The following is a description of a gene set: Human Gene Set: GSE24292_WT_VS_PPARG_KO_MACROPHAGE_DN Genes down-regulated in macrophages: wildtype versus PPARG knockout. from publication Roszer T, Menéndez-Gutiérrez MP, Lefterova MI, Alameda D, Núñez V, Lazar MA, Fischer T, Ricote M (PMID 21135166) species: Homo sapiens PPARg is a nuclear receptor that plays an important role in lipid metabolism, homeostasis and immunity. Microarray analysis of gene expression was performed in macrophages from WT and PPARg KO mice. Differentially expressed genes were selected for further analysis., and this is the list of marker genes: IFTAP, PEX13, METRNL, AXL, PNPT1, EYA1, TRIM34, CCDC9, PNISR, SERPINB6, RUFY3, KIF23, MFSD12, DNAJC9, REPS2, LAIR1, IKZF2, PLIN3, C3AR1, PSMC2, DOCK11, GNAQ, CYP27A1, LFNG, ITM2C, DENND4C, SLA (NCBI Gene Id 6503), CLN3, ITGB3BP, ARHGAP19, CWC22, OTULINL, AMOT, ENOPH1, MAN1C1, SLAMF7, GPR34, PARP12, DGKZ, SH3KBP1, APPL1, CRLF3, WDFY3, CEBPA, PSPC1, LYRM9, VPS37C, IER5, APOBEC1, GTPBP4, NCK2, KCTD21, RAPH1, TMEM109, ARHGAP17, B3GALNT1, RHOD, SULF2, POLB, JMJD1C, MRPS15, POLI, TBPL1, TRIM21, ZC2HC1A, IRF5, CD5L (CD5 molecule like), ERP29, SLC25A40, CPEB3, SLC46A3, GCC2, IFIT1B, HAUS8, MED13L, ADSS1, CALCRL, GASK1B, BCL2L11, VRK2, DZIP3, PLEC, PDXK, EHD4, ZFAND5, NIBAN1, HMOX2, CA9, OXR1, GPR19, ADAM33, GLOD4, IFIT1, DAXX, ACOT2, WWP1, NUDT13, MAPRE2, SAMTOR, ARHGAP15, DAGLB, HDAC9, PCNA, IFI35, GALNT12, SMUG1, TCF12, MX2, WDR20, TFEB (transcription factor EB), ATP6V1B2, OGFR, DNAJC2 (DnaJ heat shock protein family (Hsp40) member C2), TRIM14, PTPRO, BAIAP2L1, STARD8, SHISA9, WNK1, C1QA, FMNL3, JADE2, DNMT3A (NCBI Gene Id 1788), PLEKHM1, MPP1, OGFRL1, NME3, MTMR10, CDKN1C, SLC35B2, ITGA9, RAPGEF6, TMCC3, SNX5, DMTF1, GNA12, WDR11, LY86, OMA1 (OMA1 zinc metallopeptidase), PLEKHO1, SWAP70, CALHM6, ORMDL2, RMDN1, C19orf48P (chromosome 19 open reading frame 48, pseudogene), ISG20 (interferon stimulated exonuclease gene 20), XAF1, NT5C3A, RUNDC3B, TMEM219, OBI1, INTS4, GAPVD1, LGALS3, IFI27L2, SNW1, IFIT2 (NCBI Gene Id 8375), TMEM106A, PTK2B, LY9, RALGAPA1, ZNF281, GLG1, AHNAK2, CD72, UBA2, BRCC3, CXCL11, ZNF483, POR, PARP14, GINS1, EXTL2, COG5 (component of oligomeric golgi complex 5), CST3, TBRG1, MARCHF5, LRRC20, AHSA1, GOLGA3, CLEC10A, KCTD2, POGK, TERF2, SNX29, EVI2B, HERC6, RAD54L (NCBI Gene Id 8438), DPY19L4, HHEX, ACER3, IRGM, FBXO4, SYNJ1, PRPS2, PIK3IP1, PDLIM5, NOSTRIN, PSENEN, NDNF